Given this list of marker genes ERCC6, CBS, GLRX2, ENSG00000274276, DCTPP1, NUDT1, NUDT15, here is a description of the gene set: studied in species Homo sapiens Human Gene Set: GOBP_DNA_PROTECTION Any process in which DNA is protected from damage by, for example, oxidative stress.